Given this list of marker genes SHH, WNT5A (Wnt family member 5A), AR, SULF1, BMP7, BMP4, here is a description of the gene set: Any process that modulates the rate, frequency, or extent of prostatic bud formation, the morphogenetic process in which a region of the fetal urogenital sinus epithelium is specified to become the prostate, resulting in prostate bud outgrowth. species: Homo sapiens Human Gene Set: GOBP_REGULATION_OF_PROSTATIC_BUD_FORMATION